Given this list of marker genes HPF1, SMC5, XRCC1, FH, SMC6, ZGRF1, LMNA, ACTR2, WDR70, POLQ, SHLD2, NHEJ1, PHF1, SPINDOC, HUS1B, VCP, XPC, RFWD3, HROB, ATR, SIRT7, ACTR3, OARD1, ZBTB7A, HUS1, KAT5, EPC1, ARPC1A, NABP1, HELB, ZMYND8 (NCBI Gene Id 55497), RNF138, MBTD1, CGAS, AUNIP, SMARCAL1, ESCO2, RPA2, INTS3, TRAIP, CBX5, RBBP8, MMS22L, INIP, CHD4, SAMHD1, KAT7, ELOA, RNF8, HTATSF1, SHLD1, KDM4D, DDB2, MRE11, DMC1, MAD2L2, SETMAR, CUL5, SLF1, UFL1, RIF1, ATM, HELQ, ARPC4, SMCHD1, MACROH2A1, TP53, CYREN, CBX1, AIM2, PNKP, ARPC3, WAS, RHNO1, ERCC6, CHD1L, ERCC8, RAD50, SLF2, POLK, RPA4, WDR76, MDC1, H2AX, ADPRS, DGCR8, TOPBP1 (NCBI Gene Id 11073), PAXX, CBX3, SMARCA5, UVSSA, SMARCAD1 (SWI/SNF-related, matrix-associated actin-dependent regulator of chromatin, subfamily a, containing DEAD/H box 1), ATF2 (activating transcription factor 2), WRAP53, PARP1, NKX3-1, NBN, RAD51, XRCC5, RPA1, XRCC4, RAD17, ARPC5 (actin related protein 2/3 complex subunit 5), DYNLL1, DDB1, RNF169, MARCHF6-DT, ARPC2, TONSL, IFFO1, PRPF19 (NCBI Gene Id 27339), SIRT6, TP53BP1, SLFN11, ASF1A, PELI1, POLL, TIMELESS, PARP3, RNF168, RPA3, PARP9, SHLD3, CNTD1, EXD2, STK38, NABP2, UIMC1, POLH, RAD18, APLF, PARP2, UBQLN4, here is a description of the gene set: species: Homo sapiens Human Gene Set: GOCC_SITE_OF_DNA_DAMAGE A region of a chromosome at which DNA damage has occurred. DNA damage signaling and repair proteins accumulate at the lesion to respond to the damage and repair the DNA to form a continuous DNA helix.